Given this list of marker genes ZP2, LRP1, RPS15, VAMP5, FBXO2, RPL28, RAB1B, LHFPL6, DDR2, CLU, CCS, NENF, COL9A3, UBA52, MT3, MIA, S100A13, WNK2, RBP1, APOD, USP11, ATP1A2, CRYM, RPS11, RPL35, COL9A1, UTY, FOXD1, USH1C, RPL21, ISLR, IGFBP6, CA14, PLEKHB1, RPL32, MGP, COCH, OTOR, C19orf53, UBXN1, SELENOM (selenoprotein M), RPS5, HYI, here is a description of the gene set: Human Gene Set: ABE_INNER_EAR Through cDNA microarray analysis of gene expression in human cochlea and vestibule, we detected strong expression of mu-crystallin (CRYM; also known as NADP-regulated thyroid hormone-binding protein) only in these inner-ear tissues. In a subsequent search for mutations of CRYM, among 192 patients with nonsyndromic deafness, we identified two mutations at the C-terminus; one was a de novo change (X315Y) in a patient with unaffected parents, and the other was a missense mutation (K314T) that segregated dominantly in the proband's family. When the mutated proteins were expressed in COS-7 cells, their subcellular localizations were different from that of the normal protein: the X315Y mutant showed vacuolated distribution in the cytoplasm, and the K314T mutant localized in perinuclear areas, whereas normal protein was distributed homogeneously in the cytoplasm. Aberrant intracellular localization of the mutated proteins might cause dysfunction of the CRYM product and result in hearing impairment. In situ hybridization analysis using mouse tissues indicated its expression in the lateral region of the spiral ligament and the fibrocytes of the spiral limbus, implying its possible involvement in the potassium-ion recycling system. Our results strongly implicate CRYM in normal auditory function and identify it as one of the genes that can be responsible for nonsyndromic deafness. Genes prefentially expressed in human inner ear tissue (cochlea and vestibule), at least 10-fold higher from a mixture of 29 other tissues. from publication Abe S, Katagiri T, Saito-Hisaminato A, Usami S, Inoue Y, Tsunoda T, Nakamura Y (PMID 12471561) species: Homo sapiens